The following is a description of a gene set: Human Gene Set: HP_DECREASED_LIGHT_AND_DARK_ADAPTED_ELECTRORETINOGRAM_AMPLITUDE studied in species Homo sapiens Decreased light- and dark-adapted electroretinogram amplitude Decreased amplitude of eletrical response upon electroretinography., and this is the list of marker genes: CYP4V2, LARGE1, ACOX1, GUCY2D, ALG3, IDS, SAG, IDH3B, POMGNT1, USP45, MCOLN1, BEST1 (NCBI Gene Id 7439), LRAT (lecithin retinol acyltransferase), RHO, RGR, PPT1